Given this list of marker genes ANKRD34A, SUPT16H, FOXP1, ABCC9, CDK13, SPAG9, RASSF2, GPRASP2, ZNF532, ERCC6, RYBP, THAP1, TM9SF3, JPH4, MEX3C, SIPA1L1, GLCCI1, JAZF1, SMAD4, PRR15L, CREBRF, NPY1R, SEH1L, CACNB2, EML5, EEF1AKMT3, SERTAD3, PAIP2, DEK, TTR, NUP153, GDAP2, TRIM2, FAM107B, IGFBP3, CREM, KCNH1, ZMIZ1, TMEM47, FBXO28, SGK1, SSR3, RARB, ZFR, TNFSF11, TRH, VAV3, ZNF416 (zinc finger protein 416), ERC2, CCNY, MPZL3, SLC17A6, TRIM36, CHFR, AMPD2, TRMT61B, DGKH, MPZL1 (NCBI Gene Id 9019), UBE3A, ZNF22-AS1, PIK3CA, SHANK1, DICER1, KCNH7, CBX5, CREBBP, CXCL3, TIMP3, SRSF4, SEC24A, G3BP2, MAX, ATL2, GXYLT1, NACA, TERF2, LRRFIP1, WDR47, ERVFRD-1, SOCS6, ENPEP, MYRIP, RIOK2, C5orf22, LYSMD3, GABRP, SPMIP2, ZFX, TMEM243, FBP2, CDK1 (cyclin dependent kinase 1), USP14, PPP2R2D, TCP10L2, PPP1R9A, SH3RF1, ATP5MC3, STEAP4, BEND6, here is a description of the gene set: Genes predicted to be targets of miRBase v22 microRNA hsa-miR-4696 in miRDB v6.0 with MirTarget v4 prediction scores > 80 (high confidence targets). from publication Chen Y, Wang X (PMID 31504780) studied in species Homo sapiens Human Gene Set: MIR4696